The following is a description of a gene set: studied in species Homo sapiens Human Gene Set: GOBP_NEGATIVE_REGULATION_OF_SMOOTH_MUSCLE_CONTRACTION Any process that stops, prevents, or reduces the frequency, rate or extent of smooth muscle contraction., and this is the list of marker genes: MIR153-1, DOCK4, RGS2, ADRB2, CALCA, IRAG1, GUCY1A1, PRKG1, ADRA2A (NCBI Gene Id 92480), ARHGAP42, DOCK5, STUB1, SOD1, ADORA2B